The following is a description of a gene set: The chemical reactions and pathways resulting in the formation of a thioester, a compound of general formula RC(=O)SR' in which the linking oxygen in an ester is replaced by a sulfur atom. They are the product of esterification between a carboxylic acid and a thiol. Mouse Gene Set: GOBP_THIOESTER_BIOSYNTHETIC_PROCESS studied in species Mus musculus, and this is the list of marker genes: Pgk1, Vdac1, Ppcs, Pdk4, Mpc2, Elovl5, Acsl5, Gcdh, Elovl4, Snca, Elovl3, Pdha1, Acsl4, Dld, Acat1, Bckdk, Pdhx, Elovl7, Acsl1, Dlat, Acss2, Acaca, Mmaa, Pdk1, Acly (ATP citrate lyase), Mmut, Acsl6, Acacb, Pdha2, Elovl1, Pdk2, Acss1, Dip2a, Mlycd, Mpc1, Elovl6, Pdhb, Tpk1, Pdk3